The following is a description of a gene set: studied in species Homo sapiens Human Gene Set: MODULE_227 Genes in the cancer module 227., and this is the list of marker genes: UROS, CPOX, UGT2B7, BLVRA, ALAD, UGT2B4, BLVRB, UGT2B15, HMBS (NCBI Gene Id 5448), CP, PPOX, UGT1A6 (UDP glucuronosyltransferase family 1 member A6), FECH, ALAS2, UROD